The following is a description of a gene set: Abnormal morphology of ulna Human Gene Set: HP_ABNORMAL_MORPHOLOGY_OF_ULNA Any structural anomaly of the ulna, a bone of the forearm the extends from the elbow to the little finger. studied in species Homo sapiens, and this is the list of marker genes: SOS2, PALB2, FANCA, IHH (NCBI Gene Id 50819), MACROH2A1, SHOX (NCBI Gene Id 6473), MRAS, RRAS2, RFC2, BRAF, MAP2K1, MAF (MAF bZIP transcription factor), BRD4, LAMA5, CHSY1, ROR2, MECOM, SLX4, SOS1, B2M, GTF2I, CANT1, TMEM270, RAB3GAP2 (NCBI Gene Id 26114), TWIST1, ANAPC1, FGFR2, AGA, PRKG2, LZTR1, CCN2, RAD21, BRIP1, APC, NIPBL, HOXA11, DNAJC30, LMBR1, SPRED2, MAP2K2 (mitogen-activated protein kinase kinase 2), BCOR, SMC1A, FANCD2, KAT6B, TAF6, COLEC11, RECQL4, RAD51C, ESCO2 (NCBI Gene Id 5951), TNFRSF11A, SCARF2, GDF5 (growth differentiation factor 5), XYLT1, LRP4, TBL2, SLC26A2, FANCF, EXT1, RRAS, TBX5, PLXND1, B4GALT7, CHST3, COL2A1, BAZ1B, FKBP6, FANCI, SNRPN, CSGALNACT1, SF3B4, WNT7A, CUL7, DONSON, TBX3, STX1A, LIMK1, FLNA, TBX22, SALL4, CBL, PDE4D, BMPR1B, NOG, JAG1, XRCC2 (X-ray repair cross complementing 2), IFT43, RASA2, BRCA1, CTBP1, CCDC8 (coiled-coil domain containing 8), LETM1, METTL27, VPS37D, POR, KRAS, BRCA2, DHODH, ERCC4, RIPK4, PIGT (phosphatidylinositol glycan anchor biosynthesis class T), BICRA, DYNC2H1, NDN, COL11A1, MMP13, MAD2L2 (mitotic arrest deficient 2 like 2), EXOC6B, COL10A1, GTF2IRD1, MAGEL2, PITX1, PIEZO2, RIT1, EXT2, VPS35L, FANCL, B3GALT6, NSD2, FGFRL1 (NCBI Gene Id 54966), EIF4H, MASP1, TGFB1, FANCE, FGFR3, RAD51, RFWD3, RPL26, FANCB, GTF2IRD2, BHLHA9, BUD23, NCF1, REV3L, MMP9, PCNT, FLNB, ELN, RAF1, GSC, COMP, FANCM, MLXIPL, BGN, FANCC, CHD7, SMAD6, COLEC10, CPLX1, NRAS, SETBP1, PTPN11, B3GAT3, RBM8A, FANCG, HDAC8, PRKAR1A, OBSL1, SMC3, CLIP2, UBE2T